The following is a description of a gene set: Mouse Gene Set: GOBP_NEGATIVE_REGULATION_OF_LIPOPOLYSACCHARIDE_MEDIATED_SIGNALING_PATHWAY Any process that stops, prevents, or reduces the frequency, rate or extent of signaling in response to detection of lipopolysaccharide. studied in species Mus musculus, and this is the list of marker genes: Cactin, Ltf, Ptpn6, Acod1, Sirpa, Trib1, Tnfaip3, Defb21, Nfkbil1, Prdx2